The following is a description of a gene set: from publication Zemek RM, De Jong E, Chin WL, Schuster IS, Fear VS, Casey TH, Forbes C, Dart SJ, Leslie C, Zaitouny A, Small M, Boon L, Forrest ARR, Muiri DO, Degli-Esposti MA, Millward MJ, Nowak AK, Lassmann T, Bosco A, Lake RA, Lesterhuis WJ (PMID 31316010) Mouse Gene Set: ZEMEK_IMMUNE_CHECKPOINT_BLOCKADE_OVARIAN_CANCER_RENCA_DN Experiments were performed using Renca renal cell carcinoma cell lines. studied in species Mus musculus The authors compared the cellular composition and gene expression profiles of responsive and nonresponsive tumors from BALB/cArc, BALB/cJAusb, and C57BL6/J mice before immune checkpoint blockade (ICB) and validated the findings in cohorts of patients with cancer treated with ICB antibodies., and this is the list of marker genes: 3000002C10Rik, Zcchc4, Paxip1, 2810402E24Rik, Asgr2, Gm30238, E230013L22Rik, Sv2a